Given this list of marker genes SLC39A8, PTBP3, RRAGC, NBN, SKAP2, DDX21, PIP5K1B, PGRMC1, GDI2, AIP, NDUFAB1, ZNF45, PPIE, ABT1, ARFIP2, CD40, ADH5, CREM, SLC12A2, TRAM1, BECN1, ZNF264, KAT6B, SCP2, PRKAB1, RHOQ, STAT3, NSF (N-ethylmaleimide sensitive factor, vesicle fusing ATPase), CD63, RAD50, NCK2, DCTN3, OSBP, NFIL3, COX10, CLTC, PDE3B, RHOH, PUM2, PDLIM5, WASF2, BAG2, RNF139, UTRN, BTN2A1, PDE4B, NPTN, KLF10, YARS1, ANXA2, CYP2A6, OXSR1, RBM5, IFITM1, CLEC2B, FZD3, G3BP2, PPA1, ITM2B, CD28, RPS6KA3, SNRPB, TRIP4, PICALM, PYROXD1, PSMD11, ATP5PO, CFLAR, HSPA14, BET1 (Bet1 golgi vesicular membrane trafficking protein), PTPN1, TAX1BP1, EIF1AX, TFG, CYB5R4, UTP3, SFSWAP, DNAJA1, CSNK1A1, CLEC2D, SEL1L, PCBP1 (poly(rC) binding protein 1), USP16, SLAMF1, DAP3, PJA1, PITPNA, ECI2, PPP1R2, SYK, HSD17B12, HSP90AB1 (heat shock protein 90 alpha family class B member 1), KIFAP3 (NCBI Gene Id 22920), ARL1, RPN2, UBE2L6, NDUFA10, XDH, ATP6V1G1, M6PR, ZNF318, NEU1 (NCBI Gene Id 4758), ILK, MDH2, STS, ADA2, PTPN12, DRG1, PNP (NCBI Gene Id 4860), PTPRO, NAGK, ZNF395, SDF2, IRF2 (interferon regulatory factor 2), SARS1, SIAH2, CTBS, ITPR1, LPAR6, DHX15 (DEAH-box helicase 15, NCBI Gene Id 1665), ZW10 (NCBI Gene Id 9183), OPTN, SELENOW, PIGL, RABIF, AIMP1, SNAPC3, SEMA4D, TNFAIP8 (TNF alpha induced protein 8), CSTF2, FAS, NFKB1, GMPR2, SRPK1, LGMN, UBE2N, SRSF6, VPS4B, PEX19, VRK3, MYD88, UBE2D2, TBRG4, PRCP, EIF2AK3, PEX11B, GDE1, ALDH3A2, PXMP4, CDC16, STOML2, CRLF3, CPSF4, NFYB, CAMKK2, YWHAQ, GRM6, CIDEC, DUSP5, ATP6V1D, MRPS35, NDUFS4, PRKCI, SF3B1, PIAS1, ISG20, CNIH1, RASSF2, PNMA1, GPNMB, MARCKS, PRPSAP1, GLG1, GOLGA8A, MAPRE1 (microtubule associated protein RP/EB family member 1), MIPEP, ETF1, PTDSS1, SRD5A1, RHOB, URI1, PSMD12, BABAM2, ARHGEF7, YME1L1 (YME1 like 1 ATPase), HPCAL1, SART3, SNX6, MAP2K1, OAS3, YTHDC1 (NCBI Gene Id 91746), CCZ1, ARL5A, PTER (NCBI Gene Id 9317), SLC25A40, LCP1, DCTN4, SCFD1, SUMO3, GPR137B, SQOR, CNOT2, PSPH, DLD, CCNC, PABPN1, GYS1, EMC3, PPP3CB, AP2B1, FMR1, XPNPEP1, AICDA, RBM3 (RNA binding motif protein 3), ANP32A, DBT, EXOSC5, TPK1, RAB9A, PGM1, MED6, PRPF18, RCBTB2, ZNF141, HADHA, XIAP, POLR2C, ST8SIA4, AK4, SCAMP3, PEPD, CUL1, SLC25A5, TRAM2, SON, LIPA, PSMA5, PDK3, RBM7 (RNA binding motif protein 7), TAF9, CDC123, PSMB8, MKKS, NME6, ZNF148, AKAP10, VDAC1, ALG5, PRMT5, MICU1, B4GALT6, ADM, RIT1, IPO5, KLHDC2, SLC17A5, KLF6, COX7A2L, EIF5, MED21, TMPRSS3, NCBP3, ATP5F1B, EPOR, TTC1, BCL2L2, E2F6, MFAP1, BAG1, LEF1 (NCBI Gene Id 51176), PSAP, TMBIM6, NSFL1C, DPH1, UBE2K, SCAF11, ARAF, SQSTM1, GABPA, LAPTM4A, RIOK3, RAC2, RPL15, GATM, MRPL49, CCNB1IP1, TXNDC9, CASP7, GRSF1, IL32, EIF2S1, EIF2S2, TRIM13, MFAP3, ETNK1, POLE3, MCL1, PARP4, RFC1, GOSR2, CAP1, PRDX3, SSR2, SNRPN, EXOC5, RNF13, MKRN1, PRDX4, CUL4B, PCYT1A, GMFB, ASH2L, UBAP1, TSPAN31, RPA3, EIF2B3, TOMM20, BTG2, CCT4, ACTR2, ARFGEF1, MAP1LC3B, ALG6, JAK1, ORC4, SLC25A32, PRPF4 (NCBI Gene Id 9128), GALC, CCT2, SLC16A3, LMAN1, SMAD2, ABCG1 (NCBI Gene Id 9619), PWP1, DAZAP2, DEDD, NOLC1, MYO5A, PITPNB (NCBI Gene Id 23760), VBP1, ZFR, ANXA11, ATXN1, NCK1, ARL2BP, NMT2, ERGIC3, LIMA1, DDX24, ARL4C, CRYZ, TGOLN2, SLAMF7, GPR15, LAP3, STK17A, POLR2D, DDB1, IGHMBP2, RNF4, CREBL2, ARPC5L, STK19, MED1, CLOCK, TNFAIP1, BIRC2, SNRPB2, ZNF22, LYST, DLEU1, RNASE6, C1D, ADCY3, PSMA3, MAPKAPK5, ATXN10, ZNF274, IPO7, DNAJB9, PDCD6, IDH3B, PKIA, IGF1, MTIF2, MLH3, IDS, CBX4, APOL1 (apolipoprotein L1), RAD1, PBX3, CD59, CRADD, PSMB1, CDC23, CRK, CSDE1, DCTN6, MTF2, CDC27, CD46, TNFSF10, NFE2L2, SP2, VPS41, FARS2, GPHN, ARPC5, MBD4, KIF5B, NIBAN1, BTRC, GTPBP4, METTL13, COPB2 (COPI coat complex subunit beta 2), PSMB9, CCDC6, RC3H2, PALM2AKAP2, PRKACB, MAN2A1, LILRB1, EGLN1, CCT6B, MKLN1, RTCB (NCBI Gene Id 51493), GBF1, PTEN, GOLGA7, TMED10, ODC1, PTPRC, TLR7, PPM1A, GTPBP6, ATP6V0E1, HADHB, CUL5, USP1, ACSL1, ITPA, ELOA, PNOC, VRK2, PPP2R2A, SLC2A5, ICAM2, PPP1CC, ZNF91, BRCC3, MCCC2, CHKB, PDHX, TTC3 (NCBI Gene Id 7267), SLC38A1, GNAI3, VPS26C, YWHAZ, TGDS, GHITM, TXNRD1, ASAH1, ZNF24, TIMM17A (NCBI Gene Id 10440), PRKAG1, SNUPN, SF3A1, PFKP, GTPBP2, RBPJ, JTB, ZNF207, MAP3K7, CLP1, PDCD10, SDHA, KAT6A, RAB27A, CNOT8, SMG1P2, CAPN7, OAZ2, TMED3, CDYL (NCBI Gene Id 9425), SEC24B, THEMIS2, MRPS7, RERE, SPTLC1, CGGBP1, TRIM44, PRPS1, USP14, SLC12A7, PTPRE, GLIPR1, CAPRIN1, CKAP4, DOK2, RAB1A, GOLGA1, CD38, HSPA8, GTF2B, SF1, AZIN1, ARF4, RAB6A, KIF2A, PEX12, TMX1, MLLT10, POLR2B, ATP6V1E1, RPP14, ST13, FICD, AP3B1, COPS4, GMCL1, DUSP12, NAPA (NCBI Gene Id 8775), GRK3, HMGN4, MCM3AP, PPT1, DNAJC15, CMPK1, TUBGCP4, DDOST, TIMM23, CCNH, PTPN22, RAB4A, CD164, ATP6V1B2, GBP1, CLCN3, CREB1, SFPQ, GNB1, SMAD4, LAMTOR3, YAF2, SPAG9, NMD3, GARS1, TM9SF2, GOLGA4, UGP2, CAT, SRP72, SLC1A1, CTSS, UBE2D3, P2RX4, MCM2, MYLIP, NAT1, TRAPPC3, CD53, MEF2C, EVI2A, GEMIN4, IL10RA, GRK5, RALB, WFDC2, ATG5, PDIA5, ALKBH1, OAS2 (2'-5'-oligoadenylate synthetase 2), CTDSP2, NFATC3, FERRY3, PSMA2, MLH1, UCHL5, COPA, ZNF7, SLC38A2, RELA, USP8, RNGTT, PSMA1, RPA2, SNX3 (sorting nexin 3), WBP4, PPP1R8, GPR27, here is a description of the gene set: species: Homo sapiens from publication Spielman RS, Bastone LA, Burdick JT, Morley M, Ewens WJ, Cheung VG (PMID 17206142) Genes down-regulated in lymphoblastoid cells from the European population compared to those from the Asian population. Variation in DNA sequence contributes to individual differences in quantitative traits, but in humans the specific sequence variants are known for very few traits. We characterized variation in gene expression in cells from individuals belonging to three major population groups. This quantitative phenotype differs significantly between European-derived and Asian-derived populations for 1,097 of genes tested. For the phenotypes with the strongest evidence of cis determinants, most of the variation is due to allele frequency differences at cis-linked regulators. The results show that specific genetic variation among populations contributes appreciably to differences in gene expression phenotypes. Populations differ in prevalence of many complex genetic diseases, such as diabetes and cardiovascular disease. As some of these are probably influenced by the level of gene expression, our results suggest that allele frequency differences at regulatory polymorphisms also account for some population differences in prevalence of complex diseases. Human Gene Set: SPIELMAN_LYMPHOBLAST_EUROPEAN_VS_ASIAN_DN